Given this list of marker genes Mrps24, Hsp90ab1, Pdia6, Map4k1, Mrpl52, Calr, Sbno2, Cfl1, Actg1, Ptma, Hsp90b1, Aprt, Tubb4b, Zfp593, Cd53, Calm1, Wfdc17, Psma7, Pole4, Cd38, Ppia, Hspa5, Dnajb11, Fkbp2, Pdia3, Pfn1, Mrpl23, Sdf2l1, Nme1, Atp5mc1, Hspa9 (heat shock protein 9), Manf, here is a description of the gene set: studied in species Mus musculus Cytokines mediate cell-cell communication in the immune system and represent important therapeutic targets. A myriad of studies have highlighted their central role in immune function, yet we lack a global view of the cellular responses of each immune cell type to each cytokine. To address this gap, the authors created the Immune Dictionary, a compendium of single-cell transcriptomic profiles of more than 17 immune cell types in response to each of 86 cytokines (>1,400 cytokine-cell type combinations) in mouse lymph nodes in vivo. A cytokine-centric view of the dictionary revealed that most cytokines induce highly cell-type-specific responses. For example, the inflammatory cytokine interleukin-1β induces distinct gene programmes in almost every cell type. A cell-type-centric view of the dictionary identified more than 66 cytokine-driven cellular polarization states across immune cell types, including previously uncharacterized states such as an interleukin-18-induced polyfunctional natural killer cell state. Mouse Gene Set: CUI_B_CELL_IL10_RESPONSE_UP from publication Cui A, Huang T, Li S, Ma A, Pérez JL, Sander C, Keskin DB, Wu CJ, Fraenkel E, Hacohen N (PMID 38057668) Genes positively differentially expressed in cell type: B cell upon treatment with cytokine: IL-10 in mouse lymph nodes in vivo.